Given this list of marker genes Fbxo38, Havcr2, Xcl1, Cd274, Ulbp1, Tgfb1, Cd40lg, Pvr, Muc4, Nkg7, Prkaa1 (NCBI Gene Id 105952), Slc22a13, Mr1, Mill1, Nectin2, Hspd1, Prf1, Raet1d, Adam15, Cd24a (NCBI Gene Id 12484), Il12b, Hmgb1, Crtam, Ceacam1, Klrk1, Ywhag, Ahr, Cd160, Cd226, Hrg, Gsdme, Ufl1, Klhl22, Klre1, Il12a, Pdcd1, Il4i1, here is a description of the gene set: An immune system process that functions in the response of an organism to a tumor cell. studied in species Mus musculus Mouse Gene Set: GOBP_IMMUNE_RESPONSE_TO_TUMOR_CELL